The following is a description of a gene set: Any process that stops, prevents or reduces the frequency, rate or extent of execution phase of apoptosis. Mouse Gene Set: GOBP_NEGATIVE_REGULATION_OF_EXECUTION_PHASE_OF_APOPTOSIS species: Mus musculus, and this is the list of marker genes: Dffa, Mtrnr2l7, Cxcr3, Bcl2l1, Hspd1, Gcg, Fzd3, Cidea